Given this list of marker genes ABCB10, INHA, HIF1A, SLC6A9, ALAS1, LDB1 (LIM domain binding 1), KLF4, ALAS2, EPO, FECH, EIF2AK1, PRMT1, SLC25A37, INHBA, here is a description of the gene set: studied in species Homo sapiens Human Gene Set: GOBP_HEMOGLOBIN_BIOSYNTHETIC_PROCESS The chemical reactions and pathways resulting in the formation of hemoglobin, an oxygen carrying, conjugated protein containing four heme groups and globin.